The following is a description of a gene set: studied in species Mus musculus Mouse Gene Set: GOBP_DENDRITIC_SPINE_DEVELOPMENT The process whose specific outcome is the progression of the dendritic spine over time, from its formation to the mature structure. A dendritic spine is a protrusion from a dendrite and a specialized subcellular compartment involved in synaptic transmission., and this is the list of marker genes: Slc30a1, Lzts3, Ngef, Ngfr, Sdk1, Zmynd8, Dnm3, Grin3a, Rac1, Cdk5, Zdhhc15, Tanc2, Dlg4, Uba6 (NCBI Gene Id 66644), Ube3a, D16Ertd472e, Nlgn3, Hnrnpk (heterogeneous nuclear ribonucleoprotein K), Git1, Ulk4, Pdlim5, Pbrm1, Mapk6, Eef2k, Hdac2, Dock10, Tiam1, Neurl1a, Cdc42, Plk2, Itpka, Xlr3b, Ephb3, Abi3, Shank1, Dbnl, Disc1, Srcin1, Wnt7a, Ephb2, Lrp8 (NCBI Gene Id 16975), Ndp, Nck2, Actr2, Mfn2, Pak4, Fmr1, Eif4g2, Prmt3, Sipa1l1, Wasl, Arid1b, Grn, Foxo6, Reln, Arhgap33, Arf1, Mfn1, Ptprd, Mapkapk5, Srgap2, Dip2a, Kalrn, Lpar1, Psen1, Cask, Abi3bp, Cpeb3, Kif1a, Cdkl5, Septin7, Afdn, Dtnbp1, Hdac6, Cux2, Arf4, Opa1, Caprin2, Cfl1, Fstl4, Ppfia2, Adam10, Apoe, Ptprs, Epha5, Mecp2, Lrrk2, Ppp1r9a, Cdk5r1, Ctnnd2, Llph, Stau2, Myo5b, Nlgn2, Il1rapl1, Efna1, Shank3, Pak1, Pak3, Camk2a, Abi2, Cntnap2, Arc, Zfp365, Dhx36, Slc12a5, Pafah1b1, Itsn1, Marcks, Asap1, Camk2b (calcium/calmodulin-dependent protein kinase II, beta), Baiap2, Pten, Slc9a6, Bhlhb9 (basic helix-loop-helix domain containing, class B9), Palm, Arf6, Ephb1, Acsl4, Spire1, Camk1, Mtor, Crebbp, Pak2, Mef2c, Dscam, Nr3c1 (NCBI Gene Id 14815), Arhgap44, Dnm1l, Dbn1, Dvl1, Nlgn1, Epha4, Caprin1, Dlg5, Iqsec1, Tsc2, Il2, Actr3